The following is a description of a gene set: studied in species Homo sapiens Reactome Pathway: Intestinal absorption Nutrient absorption occurs mostly in the small intestine. Processes annotated here include the uptake of dietary cholesterol and phytosterols, and of monosaccharides. Movement of the final products of digestion out of the intestinal lumen is mediated by arrays of transporters associated with the apical and basolateral surfaces of enterocytes. part of: Digestion and absorption, and this is the list of marker genes: SLC2A5, RSC1A1, SLC2A2, NPC1L1, SLC5A1